Given this list of marker genes Cdc5l, Etaa1, Cry1, Prap1, Cdk5rap2, Ptprv, Syf2, Khdc3, Xpc, Rad50, Ccnb1-ps, Cdc5lrt5, H2ax, Ccnd1, Nsun2, Foxn3, Mad2l1, Bub1b, Cdc5lrt9, Spdl1, Hus1b, Zfp207, Rfwd3, Cdc5lrt7, Ttk, Usp44, Nae1, Rbbp8, Plk3, Cdc20 (cell division cycle 20), Rad9b, Trim39, Abraxas1, Cdca8, Fem1b, Trp53bp1, Brcc3, Blm, Diaph3, Lcmt1, E2f1, Nek1, Chek2, Stk33, Anapc15-ps, Clock (NCBI Gene Id 620729), Ccnb1 (NCBI Gene Id 268697), Plk1, Rpa2, Fancd2, Eme2, Rnaseh2b, Hsf1, Taok1, Prpf4b, Vps4a, Dtl (NCBI Gene Id 76843), Zfyve19, Ik, Zw10, Taok3, Nek11, Ptpn11, Cdc5lrt8, Trip13, Ier3, Tti1, Trp53, Atm, Chmp4c, Pcid2, Hinfp, Dgkz, Hormad1, Timeless, Tipin, Mus81, Gigyf2, Map3k20, Atrip, Topbp1, Taok2, Tex14, Eme1, Mre11a, Cdc5lrt6, Brcc3dc, Fzr1, Atf2, Mdc1, Cdc6, Prkdc, Cep63, Spc25, Pabir1, Prox1, Stk38, Hus1, Cep192, Sde2, Usp28, Clspn, D7Ertd443e, Dtx3l, Rpl24, Ndc80, Mad1l1, Tiprl, Anapc15, Creb3l1, Inip, Nuf2, Haspin, Ccar2, Fbxo4, Eif2ak4, Arhgap33os, Brca1, Trex1, Mad2l1bp, Prpf19, Mapk14, Rad51, Brd4, Setmar, Rint1, Parp9, Wac, Birc5, Rad1, Ints3, Gnb1l, Chfr (NCBI Gene Id 231600), Rps27l, Nabp1, Ppp1r10, Nabp2, Ska1, Bub3, Donson, Cenpe, Stil, Tpr, Ticrr, Aurkb, Ercc6 (excision repair cross-complementing rodent repair deficiency, complementation group 6), Dync1li1, Rhno1, Ccng1, Ska3, Babam1, Foxo4, Ints7, Knl1, Rad9a, Nbn, Incenp, Trrap, Rps6, Aurka, Lyn, Brca2, Fbxo31, Mrnip, Chek1, Wdr76, Cdt1, Mbtps2, Cdkn1a, Cdc5lrt1, Mtbp, Mbd4, Ufl1, Klhl22, Nop53, Xrcc3 (X-ray repair complementing defective repair in Chinese hamster cells 3), Dna2, Cdc14b, Zfy2, Cdk1 (NCBI Gene Id 12534), Spc24, Cdc5lrt10, Orc1, Apc, Zfp830, Uimc1, Cul4a, Bub1, Gen1, Cdc5lrt4, Babam2, Mbtps1, Cdk5rap3, Dusp1, Atr, Dot1l, Bard1, Zwilch, Zwint, Msh2, Rad17, Brsk1, Kntc1, Psmg2 (proteasome (prosome, macropain) assembly chaperone 2), here is a description of the gene set: species: Mus musculus Mouse Gene Set: GOBP_CELL_CYCLE_CHECKPOINT_SIGNALING A signaling process that controls cell cycle progression by monitoring the integrity of specific cell cycle events. A cell cycle checkpoint begins with detection of deficiencies or defects and ends with signal transduction.